Given this list of marker genes Gng7, Gnb2, Avp, Rab11fip2, Gng3, Aqp5, Gnb3, Aqp7, Gnb5, Gngt2, Gng11, Prkaca, Mip, Prkar2b, Prkacb, Prkar1b (NCBI Gene Id 19085), Aqp1, Aqp8, Aqp12, Rab11a (NCBI Gene Id 53869), Avpr2 (arginine vasopressin receptor 2), Gngt1, Gng8, Aqp11, Aqp4, Gng4, Gng5, Gng10, here is a description of the gene set: This event has been computationally inferred from an event that has been demonstrated in another species.<p>The inference is based on the homology mapping from PANTHER. Briefly, reactions for which all involved PhysicalEntities (in input, output and catalyst) have a mapped orthologue/paralogue (for complexes at least 75% of components must have a mapping) are inferred to the other species. Reactome Pathway: Aquaporin-mediated transport electronically inferred by orthology from the curated human pathway species: Mus musculus part of: Transport of small molecules